Given this list of marker genes FOXN1, LYST, IRAK4 (interleukin 1 receptor associated kinase 4), IGHG2, IGKC, CFI, here is a description of the gene set: Recurrent streptococcal infections Increased susceptibility to streptococcal infections, as manifested by recurrent episodes of streptococcal infections. Human Gene Set: HP_RECURRENT_STREPTOCOCCAL_INFECTIONS studied in species Homo sapiens